The following is a description of a gene set: species: Homo sapiens Regulation of gene expression in endocrine-committed (NEUROG3+) progenitor cells Human Gene Set: REACTOME_REGULATION_OF_GENE_EXPRESSION_IN_ENDOCRINE_COMMITTED_NEUROG3_PROGENITOR_CELLS, and this is the list of marker genes: INSM1, NEUROG3, NEUROD1, PAX4, NKX2-2